Given this list of marker genes KIRREL1, SGPL1, DAAM2, DGKE, EMP2, NOS1AP, ZAP70, YRDC, LAMB2, AVIL, SLC41A1, here is a description of the gene set: Abnormal Bowman capsule morphology Human Gene Set: HP_ABNORMAL_BOWMAN_CAPSULE_MORPHOLOGY A structural anomaly of the double-walled capsule (Bowman capsule) that opens into a renal tubule. species: Homo sapiens